Given this list of marker genes CD28, TFRC, NBN, MRNIP, TIMELESS, MEAF6, TP53BP1, SHLD2, CREBBP, MLH1, EP400, RUVBL2, RNF8 (NCBI Gene Id 9025), EPC1, HMCES (NCBI Gene Id 56941), CLCF1 (NCBI Gene Id 23529), RNF126, FANCB, UBE2B, SHLD3, PMS2, KMT5B, MSH2, TNFSF4 (NCBI Gene Id 7292), DMAP1, KAT5, WDR48, MORF4L2, RAD51AP1, ING3, PRMT1, ACTB, FUS, MRGBP, PIAS4, ERCC2, KHDC3L, SKP2, WAS, TNFSF13, WRAP53, HELQ, STAT6, PELI1, MAD2L2, HDGFL2, TRRAP, RIF1, IL2, EXOSC3, VPS72, ACTR2, MBTD1, EXOSC6, RUVBL1, IL4, PARP1, SHLD1, BRD8, TBX21, PAXIP1, ERCC6, ZCWPW1, OOEP, ARID2, NSD2, MORF4L1, ATAD5, KMT5C, ACTL6A, PRDM9, YEATS4, TGFB1, CD40, EPC2, PTPRC (NCBI Gene Id 5788), here is a description of the gene set: species: Homo sapiens Human Gene Set: GOBP_POSITIVE_REGULATION_OF_DNA_RECOMBINATION Any process that activates or increases the frequency, rate or extent of DNA recombination.